Given this list of marker genes Kansl2, Kansl1, Kansl3, Mcrs1, Wdr5, Hcfc1, Ogt, Kansl1l, Phf20, Kat8, Phf20l1, here is a description of the gene set: studied in species Mus musculus Mouse Gene Set: GOCC_NSL_COMPLEX A histone acetyltransferase complex that catalyzes the acetylation of a histone H4 lysine residues at several positions. In human, it contains the catalytic subunit MOF, NSL1/KIAA1267, NSL2/KANSL2, NSL3/KANSL3, MCRS1, PHF20, OGT1, WDR5 and HCF1.